The following is a description of a gene set: studied in species Homo sapiens Human Gene Set: HP_ABNORMALITY_OF_THE_GLENOID_FOSSA An anomaly of the glenoid fossa, also known as the glenoid cavity, which is the articular surface of the scapula that articulates with the head of the humerus. Abnormality of the glenoid fossa, and this is the list of marker genes: SCARF2, ORC1, FGFR2, LMX1B, RTL1, DYM, LYSET, DLK1, MEG3